Given this list of marker genes PPP1R11, DBI, RPS4Y1, COX7B, H2AC18, NPIPB3, CDC37, H2AZ1, ACOT7, PRDX2, S100A4, FUBP1, PPIB, CD99, COX6A1, ATP5MC3, HNRNPA2B1, COX4I1, TSC22D1, COX8A, SELENOW, RPS5, RPS25, UBB, MSN, PMAIP1, TCP1, GPX4, MANF, TPP1, SRI, NAP1L1, EEF1D, RPL10A, RPL36A, GRN, DYNLL1, SEM1, VIPR2, POLR2L, IER2, ELF3, ARF5 (NCBI Gene Id 381), PIGH, COX5A, DST, COX5B, RPL21 (NCBI Gene Id 6144), CLP1, GAL, SAT1, PTOV1, ISCU, PLP2, BAK1, PLCL1, RHOA, SOD1, NXF1, UQCRFS1, SAP18, PSMA6, NDUFA4, SNRPF, GNAT2 (NCBI Gene Id 92084), ERCC5, BTF3P13, RPS28 (NCBI Gene Id 6234), SPINT2, COX7A2, SEC13 (SEC13 homolog, nuclear pore and COPII coat complex component), UBXN1, GPS2, CCDC85B, PRDX3 (NCBI Gene Id 29017), FTH1, IFNA16, RPS9, RPL27A, UBC, RPLP0, CDH8, ATP6V0B, PFDN5, TXN, MRPL49, COX6C, here is a description of the gene set: studied in species Homo sapiens Genes up-regulated in primary tissue culture of epidermal kerationcytes after UVB irradiation. Ultraviolet B (UVB) radiation is an important inducer of many biologic changes in skin, of which keratinocytes are a key target. To gain better insight into changes in gene expression generated in the early phase after UVB exposure, we used complementary RNA (cRNA) microarray hybridization to compare differences in mRNA expression of UVB-irradiated (single dose of 100 J/m2 broad-band UVB) and sham-irradiated primary cultured human keratinocytes. Six hours after irradiation, total RNA was isolated from keratinocytes, and cRNA was synthesized and hybridized to a GeneChip expression array (Affymetrix) consisting of genes. Based on a threshold of > twofold change, genes (2.8%) were designated to be the most UVB-responsive. Surprisingly, none of these genes had been shown previously to be modulated by UVB. Conversely, several genes in the microarray that had been reported previously to be UVB- responsive by other methods showed less (< twofold) or no change. Northern blotting of seven differentially modulated genes produced results similar to those derived from microarray technology, thereby validating the accuracy of screening. Clustering based on known or likely functions indicated that among 88 upregulated genes, nine encode for cytochrome c subunits, six for ribosomal proteins, and two for regulators of apoptosis. By contrast, many of the 99 downregulated genes are involved in transcription, differentiation and transport. These findings indicate that keratinocytes respond to a single low dose of broad-band UVB irradiation by enhancing processes involved in energy production and translation, while suppressing those related to transcription, differentiation and transport. Human Gene Set: TAKAO_RESPONSE_TO_UVB_RADIATION_UP from publication Takao J, Ariizumi K, Dougherty II, Cruz PD Jr (PMID 11982916)